The following is a description of a gene set: species: Homo sapiens Human Gene Set: GOMF_ATP_DEPENDENT_DIACYLGLYCEROL_KINASE_ACTIVITY Catalysis of the reaction: a 1,2-diacyl-sn-glycerol + ATP = a 1,2-diacyl-sn-glycero-3-phosphate + ADP + H+., and this is the list of marker genes: DGKG (diacylglycerol kinase gamma), DGKK, DGKI (NCBI Gene Id 9162), DGKE, DGKA, DGKQ, DGKB, DGKD, DGKZ, AGK, DGKH